The following is a description of a gene set: Binding to a clathrin heavy or light chain, the main components of the coat of coated vesicles and coated pits, and which also occurs in synaptic vesicles. studied in species Mus musculus Mouse Gene Set: GOMF_CLATHRIN_BINDING, and this is the list of marker genes: Aftph, Epn3, Cltc, Hip1r, Sclt1, Hip1, Gpr107, Lrp1, Trpc5, Lmbrd1 (NCBI Gene Id 98639), Ap4b1, Cemip, Ap1b1, Smap1, Lrrk2, Cd2ap, Syt1, Snap91, Trpc6, Caly, Syt6, Tom1l2, Pik3c2a, Dnm1l, Plk2, Nsg1, Bcl2l1, Nsg2, Syt7, Ldlrap1, Clint1, Dnajc6, Tom1l1, Enthd1, Clta, Picalm, Tom1, Epn2, Syt4, Dab2, Clba1 (clathrin binding box of aftiphilin containing 1), Ncald (NCBI Gene Id 78450), Gak, Arrb1, Syt8, Ap2b1, Epn1, Cltb, Syt5, Syt3